Given this list of marker genes Dhps, here is a description of the gene set: Reactome Pathway: Hypusine synthesis from eIF5A-lysine electronically inferred by orthology from the curated human pathway This event has been computationally inferred from an event that has been demonstrated in another species.<p>The inference is based on the homology mapping from PANTHER. Briefly, reactions for which all involved PhysicalEntities (in input, output and catalyst) have a mapped orthologue/paralogue (for complexes at least 75% of components must have a mapping) are inferred to the other species. part of: Gamma carboxylation, hypusinylation, hydroxylation, and arylsulfatase activation studied in species Mus musculus